Given this list of marker genes Ifngr1, Eef2, Kctd12, Rgs2, Cd44, Gdi2, here is a description of the gene set: from publication Cui A, Huang T, Li S, Ma A, Pérez JL, Sander C, Keskin DB, Wu CJ, Fraenkel E, Hacohen N (PMID 38057668) studied in species Mus musculus Mouse Gene Set: CUI_CDC1_IL12_RESPONSE_DN Cytokines mediate cell-cell communication in the immune system and represent important therapeutic targets. A myriad of studies have highlighted their central role in immune function, yet we lack a global view of the cellular responses of each immune cell type to each cytokine. To address this gap, the authors created the Immune Dictionary, a compendium of single-cell transcriptomic profiles of more than 17 immune cell types in response to each of 86 cytokines (>1,400 cytokine-cell type combinations) in mouse lymph nodes in vivo. A cytokine-centric view of the dictionary revealed that most cytokines induce highly cell-type-specific responses. For example, the inflammatory cytokine interleukin-1β induces distinct gene programmes in almost every cell type. A cell-type-centric view of the dictionary identified more than 66 cytokine-driven cellular polarization states across immune cell types, including previously uncharacterized states such as an interleukin-18-induced polyfunctional natural killer cell state. Genes negatively differentially expressed in cell type: cDC1 (conventional dendritic cell type 1) upon treatment with cytokine: IL-12 in mouse lymph nodes in vivo.